The following is a description of a gene set: species: Homo sapiens Reduced density of hairs. Human Gene Set: HP_SPARSE_HAIR Sparse hair, and this is the list of marker genes: IGF1R, SNRPE, BICRA, TGM1, THUMPD1, ALOX12B, KDF1 (NCBI Gene Id 126695), NFKBIA, SMAD4, SMARCA4 (SWI/SNF related, matrix associated, actin dependent regulator of chromatin, subfamily a, member 4), WNT10A, CHD7, LIG4, NIPAL4, C3orf52, ABCA12, NTRK1, EDA2R, BLM, BRF1, TRPV3, CWC27, RIN2, SLC7A7, DPH1, WNT10B, SOX9, ATRIP, TCOF1, FSHR, TSPEAR, LMNA, SATB2, CYP17A1, EDA, SPRED2, PI4KA, HR, GNPTAB, PQBP1, NPM1, APC2, PIK3R1, CREBBP, CDSN, ZFPM2 (NCBI Gene Id 56958), PLCB4, PNPLA6, KLHL24, GJB2, PRPS1, TOGARAM1, LIPH, UBR1, KRT81, GATAD2B, MED25, GTF2H5, B3GALT6 (NCBI Gene Id 126792), NOTCH1, EXOSC2, TACR3, BANF1, MPLKIP (M-phase specific PLK1 interacting protein), USP8, CDH1, CBL, HLA-DRA, COL17A1, ATP6V1E1, LSS, CAV1, ESCO2, LIPN, STING1, MBTPS2, LAMA3 (NCBI Gene Id 3909), ALOXE3, DUSP6, ZSWIM7 (NCBI Gene Id 125150), CYP4F22, AP1B1, KRT85, BNC1 (NCBI Gene Id 646), TARS1, LHB, PYCR1 (pyrroline-5-carboxylate reductase 1), WDR19, FAM111B, LAMB3, PIGL, ODC1, NUP107, PPP1R13L, PLK4, ATR, TRAF6, DHX37, NSRP1, EXT2 (exostosin glycosyltransferase 2), EPS8L3, MAF, GNRHR, MTX2, TBX3, CKAP2L, WLS, IFT52 (intraflagellar transport 52), PTPN22, MSH4, ATP6V1A, CCBE1, MAP2K2, TMEM147, KDM1A, KRT17, RNU4ATAC, FOSL2, GTPBP2, SPRY4, ITGA3, ARID1B, PCNT, SKIC3, LTV1, ST14, MRPS22, SMARCE1, CACNA1G, KDM4B, EOGT, CLMP, NF1, DSG1, NDUFA6, TERC, XRCC4, SMARCA2, ATP6V0A2, MAP3K1, ZBTB20, WWOX, TOMM7, NFIX, CACNA1C, NOP10, CAMK2B, EXT1, PUM1, KRT83, ALX1, EIF5A, ARID2, PRIM1, DNA2, SKIC2, SPRTN, MARS1, FGF8, EZH2, TYMS, SPIDR, PERP, DLX4, POLR3A, CARS1, NECTIN4, TP53, ARID1A, DNMT3A, MAP2K1, NSMF, AHSG, IFT43, OCRL, ASPRV1, NSD1, PRKD1, LAMC2, TRMT10A (tRNA methyltransferase 10A), DSG4, SOX11, POP1, EBP, HOXC13, UBE3B, HSPA9, SEMA3E, PROKR2 (prokineticin receptor 2), RIPK4, POC1A, PORCN, KRT71, ERCC2, SMARCC2, EDNRA, ATP7A, ERCC8, KRAS, SULT2B1, CEP57, TRAIP, TAC3, KIFBP, CSGALNACT1, HS6ST1 (heparan sulfate 6-O-sulfotransferase 1), POLR3H, RBBP8, PKP1, BRAF, FAT4, KRT86, SHOC2, IKBKG, GTF2E2, AR, ITGB6, PSMC3IP, NUP85, TINF2, GATA4, PSMB8, CHD6, FIG4 (NCBI Gene Id 9896, FIG4 phosphoinositide 5-phosphatase), ARHGAP31, CANT1, DCAF17, MSX1, GNB2, NR3C1, NRAS (NCBI Gene Id 4893), VAMP7, ADNP, SPINK5, FEZF1, CLDN1, RNF113A, PHF6, CTC1, AXIN2, POGZ, ERCC6 (NCBI Gene Id 282965), FLNA (NCBI Gene Id 8272), USP48, ANOS1, KISS1, VAC14, PARN, KRT74, TFAP2A, SREBF1, SMARCB1, DNAJC21, NHLH2, PROK2, WDR35, ANTXR1, AXL, XYLT1, IFT122, CDC42BPB, MGAT2, SRA1, ANAPC1, NR0B1, KMT2B (NCBI Gene Id 9757), CDH3, FGFR1, DPH5, KANK2, EDARADD, SLC25A24, PCGF2, ZMPSTE24, LPAR6, MDM2, NR5A1, CEP152, CCDC141, KMT2D, TAF1, CBS, ALDH6A1, WDR11, ALX4, APCDD1 (APC down-regulated 1), C18orf32, SLC32A1, DLL4, FAS, IRX5 (NCBI Gene Id 10265), WT1, NSUN2, FMR1, HRURF, USB1, DSP, TERT, JUP, DCLRE1B, RBPJ, PRMT7 (NCBI Gene Id 54496), AARS1, COL11A1, ATRX, BCORL1, GJA1, MESD, DPH2, PDGFRB, SF3B4, ASXL3, DSC3, PPP1R15B, HDAC4, GJB6, CST6, EDAR, RNU12, CDH23, MAPKAPK5, KCTD1, CYB5A, DOCK6, SEC23A, TWIST2 (NCBI Gene Id 117581), GSN, ACD, KRT25, IFT140, OFD1, PTDSS1, FOXL2, PPP1CB, FGF17, DKC1, SRY, TSR2, KREMEN1, WRAP53, ATP2B1, DPF2, DOLK, FSHB (NCBI Gene Id 2488), HPD, TP63, GNRH1, NEPRO, SOX18, CTSC, NECTIN1, BMP15, B4GALT7, RECQL4, SDR9C7, SMARCD1, H3-3B, ERCC3, WRN, UBA2, ITGB4, PPP2R3C, ALDH18A1, NHP2, CENPE, ADAMTS3, RAD21, FRMD4A, LIFR, CRIPT, KISS1R, SOX4, RPL21, KAT6B, HRAS, TRPS1, MED12, ORC6 (origin recognition complex subunit 6), RMRP, BRCA1, RTEL1, TTC7A, IPO8